The following is a description of a gene set: In dendritic cells, expression of the H3K9me3 demethylase JmjD2d is upregulated by LPS stimulation. To identify genes whose induction by LPS depends on JmjD2d activity, we performed a microarray analysis of wild-type and JmjD2d-knockdown dendritic cells, before and after stimulation with LPS. from publication Zhu Y, van Essen D, Saccani S (PMID 22633489) species: Homo sapiens Human Gene Set: GSE32255_WT_UNSTIM_VS_JMJD2D_KNOCKDOWN_4H_LPS_STIM_DC_DN Genes down-regulated in dendritic cells: unstimulated wildtype versus KDM4D knockdown (shRNA) stimulated by LPS., and this is the list of marker genes: PTTG1IP, SLC25A19, GFPT2, ITIH5, STK10, PLS3, MOB1B, BACE2, SH3BP4, SLC36A1, STARD4, KHNYN (KH and NYN domain containing), UBASH3B, TFRC, PNP, DUSP3, ATRX, STX2, HSPA4, C2CD2, RPS6KA1, NUDCD2, PHLDA1 (NCBI Gene Id 22822), PCK2, ATP8A1, SNX13, TPD52, ICA1, CHCHD2, TMEM30A, MLF1, TMTC2, CRYZL1, NPM2, SETDB2 (NCBI Gene Id 83852), LACTB2, TEC, PSMD6, MARCHF8, HMGCS1, SPIN1, ATP6AP2, KDSR, PAFAH1B2, LRRC57, MTDH, SAMD12, RIPK3, ARHGEF12, LRRC49, PADI2, FBXL5, PTGS1, KATNAL1, NDRG2, GATA3, PRKCZ, FUCA2, NAV2, ADCK5, DST, CTPS2, TSPAN13, SYTL1 (NCBI Gene Id 84958), VCL, ANP32B, S100A1, TMEM64, CD99L2, TUBB6, ANXA4, SSR1, MID2, ATCAY, EPCAM, PHLDA3, CASTOR2, MOSPD2 (NCBI Gene Id 158747), CAV2, ZFP36, DNPH1, FAR1, PLIN2, ARRDC4, PLCL1, SLC37A2, SLC12A5, ATF3, KIT, LMNA, LGALS3, SRXN1, RASSF6, PLCB4, CCR9, SLC38A10, CCL2, ATP6V0A1, PCYT1A (NCBI Gene Id 5130), YPEL2, ASPH, GNAQ, LARS1, CD69, TSC22D1, RAPSN, DSC1, GGTA1, SHE, RAB5A, ADSS1, ALDH9A1, UPF3B, HSD17B7, MAPKBP1, FAM114A1, CCNG2, DCTD (dCMP deaminase), ZFP36L1, EIF4E3, PSMC6, PYGB, RBM24, TGFBR1, DHCR24 (NCBI Gene Id 9800), APH1B, TMEM43 (NCBI Gene Id 79188), ARHGAP27, CSNK1A1, NUDT2, UBXN7, ZFP1 (NCBI Gene Id 162239), PPP4R4, LONP2, ITGAV, FMN1, CPD, PSAT1, AGPAT4, STK24, TNFRSF9, ARL5A, AKAP7, TDRD3 (NCBI Gene Id 81550), GGT7, TCN2, NCKAP1 (NCBI Gene Id 9864), SNUPN (NCBI Gene Id 10073), NPAS2, ECHDC2, FAH, MIR24-2, PDE1B, LAPTM4A, FAM133B, GAS2, IL13, GLUD1, OGN, ARMCX1, ARMCX3, SCAMP1, RTN4, BCO2, SLC9A6, RPN1, CDKN2B, IRAK2, IL1R2, GALNT3, YWHAZ, EML1, CANX